Given this list of marker genes NME3, UCK1, NME5, NME7, NME6, UCK2, NME9, CTPS1, UCKL1, NME4, NME2P1, CAD, NME2, CTPS2, NME1, here is a description of the gene set: Human Gene Set: GOBP_PYRIMIDINE_RIBONUCLEOSIDE_TRIPHOSPHATE_BIOSYNTHETIC_PROCESS The chemical reactions and pathways resulting in the formation of pyrimidine ribonucleoside triphosphate, a compound consisting of a pyrimidine base linked to a ribose sugar esterified with triphosphate on the sugar. species: Homo sapiens